Given this list of marker genes ANKH, MMP2, SLC34A3, CCDC134, GLB1, FARSB (phenylalanyl-tRNA synthetase subunit beta), ADAMTS10, SFRP4, PTH1R, CLCN5, XYLT2, PIGA, PRKG2, SMS, CYP2R1, TENT5A, VDR, AKT1, SERPINH1, CYP27B1, FBN1, TMEM53, TMEM38B, TNFRSF11A, here is a description of the gene set: Abnormal thinning of the cortical region of bones. Human Gene Set: HP_THIN_BONY_CORTEX Thin bony cortex studied in species Homo sapiens